The following is a description of a gene set: Multipotential naïve CD4+ T cells differentiate into distinct lineages including T helper 1 (Th1), Th2, Th17, and inducible T regulatory (iTreg) cells. The remarkable diversity of CD4+ T cells begs the question whether the observed changes reflect terminal differentiation with heritable epigenetic modifications or plasticity in T cell responses. We generated genome-wide histone H3 lysine 4 (H3K4) and lysine 27 (H3K27) trimethylation maps in naïve, Th1, Th2, Th17, iTreg, and natural (n)Treg cells. We found that although modifications of signature cytokine genes (Ifng, Il4, and Il17) partially conform to the expectation of lineage commitment, critical transcription factors such as Tbx21 exhibit a broad spectrum of epigenetic states, consistent with our demonstration of T-bet and IFN-gamma induction in nTreg cells. Our data suggest an epigenetic mechanism underlying the specificity and plasticity of effector and regulatory T cells and also provide a framework for understanding complexity of CD4+ T helper cell differentiation. from publication Wei G, Wei L, Zhu J, Zang C, Hu-Li J, Yao Z, Cui K, Kanno Y, Roh TY, Watford WT, Schones DE, Peng W, Sun HW, Paul WE, O'Shea JJ, Zhao K (PMID 19144320) Human Gene Set: GSE14308_TH17_VS_NATURAL_TREG_UP studied in species Homo sapiens Genes up-regulated in comparison of Th17 cells versus natural regulatory T cell (Treg)., and this is the list of marker genes: ABCB6, POLR1C, KLHL10, ECI2, TBC1D32, HCLS1, MOXD1, PDE7A, NDUFAB1, OTULIN, SIRT4, SBNO2, BMAL1 (basic helix-loop-helix ARNT like 1), HS2ST1, RSPH3, DHRS1, CAMK2B, TMEM45A, PIGZ, MCF2L, LDAF1, WAPL, NEMF, HADH, ADCY6, RPA3, AAAS, ACTL6A, POLR2F, GSR, GAS8, CCNC, ACAA2, HMGB2, SLC49A4, GIN1, CDK14, NEDD8, TSPYL4, RNF19A, TRAPPC2L, INHBA (inhibin subunit beta A), RTRAF, IGFBP3, ZSCAN12, ANAPC15, TUBG2, IMMT, DEPP1, SLC26A11, FOXG1, MFSD2A, NDUFA12, PRPF18, GPRC5A, CDC14B, TUBE1, RBP1, SNRPN, FBXO32, RMDN2, SLC6A13, BORCS7 (NCBI Gene Id 119032), FUCA2, NRIP1, SCML2, PON1, SRSF10, MRPS12, MRPS9, IFT46, DOCK7, FANCD2 (NCBI Gene Id 2177), CCDC181, MIF (NCBI Gene Id 4282), GALNT3, NDE1, PRDX5, RPS6KA3, CELA1, MED9, HABP4, TOM1, MATCAP2, AGTRAP, SNF8, TTL, STX7, B9D2, DOHH, POLR3K, SKAP1, MTA3, PPIL2, CSF2RA, CCDC92, DBI, KIT, RAB8A, UTP11, SRI, CD4, ITGA3, ATP6V1G1, CHCHD2, AMMECR1L, NDUFB2, RTKN2, SKA3, DQX1, DLEU7, TFPI, PDCD6IP, UTP6, PRKAR2A, POP7, SLC66A3, BSCL2, MINPP1, TEDC1, THAP1, WDR53, TEN1, AEN, BECN1, GNL2, HIKESHI, RAD51AP1, NAAA, MTHFD2, B9D1, NXPE3 (NCBI Gene Id 91775), GAB2, LONP1, MEGF9, CNIH1, MAP1LC3A, ARHGAP19, SPSB2, SNAI3, FMO2, SPAG4, RAB33A, MBOAT2, GAPDH, TRIM72, DCTN5, CTNNBIP1, KAZALD1, ZNF414, SPEF2, OGFRL1, PES1, PAICS, DDX6, STC2, TXNDC16, XRN2, KLHL40, CISD1, RTCA, RNF115, DENND11, S100A1, TIPIN, ESRRB, GGT7, GYG1, DNAJC3, HSPA8, TMEM18, PPP3CC, PBLD, UBE2E2, GDI2, IZUMO4, ZBTB44, B3GALT5, OTUB2, FDFT1, MIB1, CD3G, THOC7, CDC123, DIO3OS, PAX6, MED20, CUL1, YIPF5, KPTN, DHDH, HDAC3, EXOC6, COMMD10, PRKCSH, YBX3 (NCBI Gene Id 8531), MRS2, ZHX3, CCDC34, CISD3